The following is a description of a gene set: Human Gene Set: GOMF_DNA_EXONUCLEASE_ACTIVITY studied in species Homo sapiens Catalysis of the sequential cleavage of mononucleotides from a free 5' or 3' terminus of a DNA molecule., and this is the list of marker genes: MEIOB, PLD4, DCLRE1C, AEN (apoptosis enhancing nuclease), RAD1, REXO2, EXO5, FEN1, TREX1, APEX1 (apurinic/apyrimidinic endodeoxyribonuclease 1), EXD2, APEX2, TREX2, POLG, POLD1, DCLRE1B, POLE, ISG20, MRE11, RAD9A, DCLRE1A, TATDN1, MGME1, PLD3, EXO1, APTX